The following is a description of a gene set: species: Homo sapiens CpG 1826 binds to Toll-like receptor (TLR)9, whereas influenza virus PR8 activates pDC via TLR7. Differential stimulation of pDCs is expected to result in unique activation mechanism(s) leading to a different phenotypically and functionally matured pDC We used microarrays to detail the global programme of gene expression underlying the maturation process of pDC activated with CpG 1826 and influenza virus PR8. We identified a distinct expression profile of upregulated immunomediators. Genes up-regulated in plasmacytoid dendritic cells (4h): CpG oligodeoxynucleotide 1826 versus influenza virus infection. Human Gene Set: GSE7831_CPG_VS_INFLUENZA_STIM_PDC_4H_UP from publication Iparraguirre A, Tobias JW, Hensley SE, Masek KS, Cavanagh LL, Rendl M, Hunter CA, Ertl HC, von Andrian UH, Weninger W (PMID 18029397), and this is the list of marker genes: MRPL23, RPL3, EXOC3L1, GPC1, LAS1L, UBE3B, DUBR, URI1, PKD1, YBEY, BPNT2, SMPD2, ZNF629, ADGRD1, PBX3, PARK7, FAM241B, RRP7A, CISH (cytokine inducible SH2 containing protein), ATRAID, GABARAPL1 (NCBI Gene Id 23710), TNS1, SNHG8, PARN (NCBI Gene Id 5073), CDK9, RBM34, TMEM143, GSTT1, MAP3K4, TMEM229B (NCBI Gene Id 161145), COQ10A (NCBI Gene Id 93058), EPB41L4B, NPC2, CSAD, COX11, BAG4, LMAN2L, TMEM134, PKP2, ABHD8, RHBDF1, DOK1, SMG6, COL25A1, TRH, TOMM70, FAM110C, ELAC1, TSR1, RMDN3, HSD17B12 (hydroxysteroid 17-beta dehydrogenase 12), RBM19, GTF2I, WDR83, AKTIP, NDRG2, IFNAR1, TECPR1, RHOF, QTRT1, TOE1, VCP, MEAK7, YPEL3 (NCBI Gene Id 83719), USE1, IDI1, CACFD1 (calcium channel flower domain containing 1), AP3M2, MFSD5, ACOT8, SLC49A4 (solute carrier family 49 member 4), NDUFAF3, TBC1D17, MUL1, CISD3, PYGO2, CNPY4, P3H3, PAK1, WFDC1, PTGR1, STAT1, GPI, STARD10, PRMT2 (protein arginine methyltransferase 2), CRCP, PMEL, BLCAP, B3GLCT, SAT1, AIRIM, RGMB, ZMAT3, ITGB6, ARL3, SULT1A1, ATP10D, BLZF1 (basic leucine zipper nuclear factor 1), NDN, PPP1R37, ABHD13, PUS1, LSR, GPR108, PRR5, PEX11A, ACP6, ACOT11, PLRG1, COG3, NAXE (NCBI Gene Id 128240), BICRA, CXCL6, FBXO27, RTRAF, CLSTN1, USP27X, TMUB1, GDA, C19orf12, RAB3IP, ROBO4, CBR3, HLA-DQA1, TAF1C, SBSPON, EIF5, ARPP21, WTIP, GOLGB1 (golgin B1), NBAS, EMC1, SAR1A, RXRA, GOSR2, ACOX1, MRPS33, FAM219B, NFASC, GIMAP5, LIX1L, MRPL11, PRKCH, IP6K1, MAP3K20, TXNL1, URGCP, TTC3, UBQLN3 (ubiquilin 3), VMAC, MDP1, RFWD3, MTURN, UNC13D, KBTBD2, HMOX2, ZNF653, CCDC39, OSMR, TIMP2, GABARAPL2 (NCBI Gene Id 90769), GHDC, MECR, POLR2M, IRF6, FSCN1, RYK, DGKG, MAGED1, PCED1B (NCBI Gene Id 91523), RPRM, PA2G4, DDX47, FAM114A1, MBOAT2, WDFY1, BMP2, TRPC4AP, LDB1, NGDN, HNRNPDL, SLC22A5, HACD4, SLC66A2 (solute carrier family 66 member 2), CYP26B1 (NCBI Gene Id 56603), SORBS1, EGFL6, SBDS, PHF5A, ZG16, SEC63, ATP1B4, BEND3, ZNF420, BATF2, FTO, CLPX, XPO7 (exportin 7), CLU, FOLR1